Given this list of marker genes LBR (NCBI Gene Id 653311), SNORD116-1, H3-3B, CTCF, BAZ1B, CLIP2, LIMK1, COL11A1, WNT7A, FLNA, ARSK, KIF22, IDUA, ATRX, MATN3, TONSL, ATP7A, PRKACB, MAP2K2, RAB33B, CCN6, CBS, BUD23, CTNS, MAPK8IP3, KRAS, MAP2K1, LMOD3, GLI1, CSGALNACT1 (NCBI Gene Id 55790), GTF2IRD2, SPTBN1, CYP19A1, COL2A1, PHLDB1, IFT57, HS6ST1, B3GALT6, NEPRO, GTF2IRD1, IDH1, NCF1, EXT2, UGP2, ENPP1, SNORD115-1 (small nucleolar RNA, C/D box 115-1), DYM, MPZ, COL9A2, RAD21, TGFB1, VPS37D, SFRP4, GALNS (galactosamine (N-acetyl)-6-sulfatase), METTL27 (methyltransferase like 27), IDH2, MCTP2, PTH1R (NCBI Gene Id 5745), STX1A, CLCN7, ADNP, SERPINH1, NPAP1, GUSB, NSD1, COL9A3, LONP1, BCOR, GAN, TNFSF11, PHEX, TFE3, CAMK2A, ACTA1, NEB, RFC2, LIFR, FN1, SKI, MMP13, CFL2, VDR, TUBB3, KAT6A, MKRN3, COL10A1, SLC26A2, TGDS, ZEB2, IFT172, KIF7, TRPS1, NF1, TBC1D7, SF3B2, RAB23, SLC10A7, NAA60, SCARF2, PLAAT3, P4HTM, CBFB, RUNX2, ACAN, OCRL, RPGRIP1L, CTC1, VPS13B, SPART, IFIH1, ELN, NDUFAF6, BMP4, COL1A2, MEGF8, RSPRY1, BPNT2, CLDN16, HBB, GNPTG, GLB1, PEPD, MAGEL2, TBL2, PRKACA, ZNF699, FKBP6, BRF1, GTF2I, HSPG2, TRPV4, IPO8, BRAF, COL9A1, EIF4H, DYNC2LI1, EVC, ORC1, PWRN1, PWAR1, CENPT, PRKG2, DNAJC30, COG5, IARS2, PMP22, ZPR1 (NCBI Gene Id 95155), MTX2, EIF2AK3, NOTCH2, CHST3, HERC2, SHOX, KLHL41, EVC2, NKX3-2, ZBTB20 (zinc finger and BTB domain containing 20), HS2ST1, ARSB, TPM2, COMP, FBN1, TMEM270, MAN2B1, EXT1, PUS3, HEATR3, B3GAT3, here is a description of the gene set: species: Homo sapiens Genu valgum Human Gene Set: HP_GENU_VALGUM The legs angle inward, such that the knees are close together and the ankles far apart.